The following is a description of a gene set: Human Gene Set: GOBP_EMBRYONIC_EYE_MORPHOGENESIS studied in species Homo sapiens The process occurring in the embryo by which the anatomical structures of the post-embryonic eye are generated and organized., and this is the list of marker genes: RARB, IFT172, WNT5A, KDM2B, WNT16, ALDH1A3, PAX2, STRA6, HIPK1, HIPK2, MFAP2, TFAP2A, FBN2, FZD5, TBX2 (T-box transcription factor 2), FRS2, SIX3, CRYAA, FOXL2, VAX2, PROX1, EFEMP1, CITED2, RARG, TH, BMP7, SP3, FOXF2, MFAP5, SOX11, PAX6, FBN1, ZEB1, TWIST1, IHH, PHACTR4